Given this list of marker genes KCNJ8, IFT122, CANT1, CREBBP, BMP2, EFNB1, SATB2, KIAA0753, NXN, FLI1, NIPBL, PTHLH, GATA4, ACVR1, KIF7, FGFR3, ACTB, EP300, HOXD13, ERF (NCBI Gene Id 2077), RAB23, SALL1, IHH, BHLHA9, TBR1, MAP3K20, FGFR1, SALL4, NR4A2, HYLS1, CTCF, FGFR2, ROR2, GLI3, NEK1, DACT1, TWIST1, FIG4, SMO, GPC4, ABCC9, C2CD3, SUMF1, VAC14, here is a description of the gene set: Abnormal hallux phalanx morphology species: Homo sapiens Human Gene Set: HP_ABNORMAL_HALLUX_PHALANX_MORPHOLOGY